Given this list of marker genes APPBP2, FXYD5, MLF1, EIF2S1, AGK, FTH1, PDHA1, SRP72, CCL2, MCCC2, FERMT1, UBE2W, HSPE1, CRIPT, RNF11, SNRPD1, ARL1, AXL, here is a description of the gene set: studied in species Homo sapiens Dysadherin, a cancer-associated membrane glycoprotein, down-regulates E-cadherin and promotes cancer metastasis. This study examined the role of dysadherin in breast cancer progression. Expression of dysadherin was found to be highest in breast cancer cell lines and tumors that lacked the estrogen receptor (ER). Knockdown of dysadherin caused increased association of E-cadherin with the actin cytoskeleton in breast cancer cell lines that expressed E-cadherin. However, knockdown of dysadherin could still suppress cell invasiveness in cells that had no functional E-cadherin, suggesting the existence of a novel mechanism of action. Global gene expression analysis identified chemokine (C-C motif) ligand 2 (CCL2) as the transcript most affected by dysadherin knockdown in MDA-MB-231 cells, and dysadherin was shown to regulate CCL2 expression in part through activation of the nuclear factor-kappaB pathway. The ability of dysadherin to promote tumor cell invasion in vitro was dependent on the establishment of a CCL2 autocrine loop, and CCL2 secreted by dysadherin-positive tumor cells also promoted endothelial cell migration in a paracrine fashion. Finally, experimental suppression of CCL2 in MDA-MB-231 cells reduced their ability to metastasize in vivo. This study shows that dysadherin has prometastatic effects that are independent of E-cadherin expression and that CCL2 could play an important role in mediating the prometastatic effect of dysadherin in ER-negative breast cancer. from publication Nam JS, Kang MJ, Suchar AM, Shimamura T, Kohn EA, Michalowska AM, Jordan VC, Hirohashi S, Wakefield LM (PMID 16849564) Genes down-regulated in MDA-MB-231 cells (breast cancer) after knockdown of FXYD5 by RNAi. Human Gene Set: NAM_FXYD5_TARGETS_DN